The following is a description of a gene set: Genes predicted to be targets of miRBase v22 microRNA hsa-miR-548at-3p in miRDB v6.0 with MirTarget v4 prediction scores > 80 (high confidence targets). from publication Chen Y, Wang X (PMID 31504780) Human Gene Set: MIR548AT_3P studied in species Homo sapiens, and this is the list of marker genes: PCBP2, ABHD17B, SNAP47, MEX3C (mex-3 RNA binding family member C), RASSF3, PRPF40A, IL1RAP, CDK17, SLC25A36, PSPC1 (NCBI Gene Id 55269), EMSY, GNAQ, SLC39A14, PSORS1C2, SMC3, DOCK10, TRIM66, TMEM33, TIPARP, OGT, ROBO1, ZNF704, CNOT7, EXOC8, ZNF287, PJA1, ZMYM2, UGDH, RNF185, CAB39, SENP8, CHD4, TTC28, CCNA2, VAPA, RFX3, VTI1A, SNRPC, SRSF10, ASTN2, CDH13, BAHCC1, AEBP2, PARP12, DACT1, FBXO33, MIB1, ZC3H12C, DDX3Y, ZMYND11, DPY19L1, MBTD1, RNF169, HSD17B12, ATF7, RBM7, PTBP3, ZMAT3, TEAD3, SSB